The following is a description of a gene set: Human Gene Set: HP_ABNORMAL_MASTOID_MORPHOLOGY studied in species Homo sapiens An abnormality of the mastoid process, which is the conical prominence projecting from the undersurface of the mastoid portion of the temporal bone. Abnormal mastoid morphology, and this is the list of marker genes: ANKH, MALT1, NBN, RAG2, RAG1, DOCK11, CDH11, TPP2, CTSK, SLC39A14, PAX1 (paired box 1), DLX3